The following is a description of a gene set: Bcl6 germline deletion causes a prominent inflammatory disease, owing to over-expression of Th2 cytokines, and affects the properties of B cells prior to immunization. Therefore we established the B cell-specific Bcl6 deletion mice and analyze the gene expression of naive B cells under physiological conditions. Genes up-regulated in follicular B lymphocytes with BCL6 knockout: heterozygotic versus homozygotic strains. from publication Kaji T, Ishige A, Hikida M, Taka J, Hijikata A, Kubo M, Nagashima T, Takahashi Y, Kurosaki T, Okada M, Ohara O, Rajewsky K, Takemori T (PMID 23027924) studied in species Homo sapiens Human Gene Set: GSE28737_BCL6_HET_VS_BCL6_KO_FOLLICULAR_BCELL_UP, and this is the list of marker genes: CC2D1A, IRF6, TANC1, BRI3, ECE2, TMEM198, NDUFA11, MYL11, CLEC1B, CASQ1, FNDC7, RBM47, GCSAM (NCBI Gene Id 257144), PPIL2, CTBP2 (NCBI Gene Id 87435), CWH43, DGKH, TSPYL2, ARSB, HECTD4, ZFYVE21, CD44, VIM, STARD10, YWHAG, SEC61B, CHD4, IFT43, TKFC, USP22, NHLRC2, FLOT2, MAB21L3, ERC1, RPS6KA2, MVB12A, PLAAT3, PITPNM1, SNED1, PBX1, OSTC, GPX7, UNC45A, CDC42BPG, NME6 (NCBI Gene Id 10201), ALG11, OXCT1, MCRIP2, SART3, ZNRD2, CCL22, ELAC2, ADRM1, ZNF318, TWNK, UBE2L3, MTMR10, HSD17B6, SOCS1, GON4L, PCNX3, NCKIPSD, PTGER2, ECE1, PLPP1, SPATA3, TNNI2, PRDX1, SPG11, IFT172, MLC1, ATOX1, GFUS, ZNF703, ADPGK, MYCL, TUBB2A, RAB43, FBXO4, RPL39, ATP5F1E, CAPN9, FHIP1B, CDH15, FNBP1, SEPSECS, GOT2, NBAS, MOCOS, HEG1, MLEC, PPARGC1B, ABCG1, ITGAE, PPP2R1A, ZBTB8B, DNAAF5, GIT1, MEN1, MBTPS1, CLASP1 (NCBI Gene Id 23332), TOR1B, CHURC1, RNF217, SLFN5 (schlafen family member 5), SELENOM, MRPL42 (NCBI Gene Id 64974), DBN1, CRYBB2, SNRPG, CRYGS, LEPROTL1, KCTD6, HK3, PRKRA, TRPC4, MRPS28, HDAC4, SIK2, TBC1D25, PPIL6, ZZEF1, SHMT2, DGKZ, NRIP3, RHEBL1, SNX24, BRDT, SOWAHC, SLC2A13, SF3A1, PLCB3, PRKX, APOBR, TIMM8B, AKAP9, SLC12A7, MPRIP, CORO7, CRIP1, DCUN1D3, TTC23L, TWF1, FOCAD, UQCC2, RPS16, PKD1, CRYAB, ZNF341, LRRC8A, RGS14 (NCBI Gene Id 10636), ARMCX3, MINDY3 (NCBI Gene Id 80013), GAS2L1, CSNK1D (NCBI Gene Id 1453), PRELID2, FNIP2, REG3A, FCRLA, AADAT, NCDN, NPEPL1, CNP, OMD, MRPL36, S100A8, STX3, GTPBP6, SH2B1, DNMBP, PLA2G15, ABL2, ATP6V1B2, TRPV1, CUL9, MRPL23, HPS4, XPO5, TKTL1, S100A1, MICAL2, ATXN7L3B, MGST3, SNX25, SLC11A1, BAG1, ASB9, COG2, RABGAP1L, THAP7, VWF, LIPA, IRF8, SLC1A5, CLDN15, TECPR2, PDCD5, MTMR14, ARPIN, LRRC31